The following is a description of a gene set: Abnormal preputium morphology Human Gene Set: HP_ABNORMAL_PREPUTIUM_MORPHOLOGY An abnormality of the retractable fold of skin that covers the tip of the penis. studied in species Homo sapiens, and this is the list of marker genes: FANCA, ERCC4, CTCF, FANCM, APC2, FANCB, FANCF, RFWD3, MAD2L2, SIN3A, KDM6A, DKC1, FANCG, BRCA1, MAMLD1, FANCE, FERMT1, EIF4A2, KMT2D, FANCC, PALB2, CENPT, FANCI, FANCL, FANCD2, AR, UBE2T, BRCA2, PQBP1, ERMARD, RAD51, SLX4, RAD51C, XRCC2, NSD1, BRIP1